The following is a description of a gene set: Any process that results in a change in the behavior of an organism as a result of a pain stimulus. Pain stimuli cause activation of nociceptors, peripheral receptors for pain, include receptors which are sensitive to painful mechanical stimuli, extreme heat or cold, and chemical stimuli. species: Mus musculus Mouse Gene Set: GOBP_BEHAVIORAL_RESPONSE_TO_PAIN, and this is the list of marker genes: Mtor, Scn11a, P2rx2, Vwa1, Kcnip3, Thbs1, Scn3a, Thbs4, Grik1, Osm, Tacr1, P2rx4, Grin2b, Ntrk1, Lpar5, Adam11, Runx1, Tspo, Pirt, Cacna1e, Capn2, Scn10a, Gria1, P2rx3, Htr7, Cacna1a, Cntnap2, Crhr1 (NCBI Gene Id 12921), Scn9a, Akt1, Trpv1, Git2